Given this list of marker genes NBEA, PMEL, SLC7A6OS, PRKG2-AS1, PRC1-AS1, MROH7, TTLL4, GEN1, BEST1, PLCE1, SPART-AS1, TYRP1, PKNOX2, HMGB1P35, TMEM135, LINC01703, RBM11, TYR, GPR143, DCT, RPL32P32, SMG1P6, NYX, VEPH1, COL8A1, DMXL1, KCNQ4, UGT3A2, H1-9P, RDH5, RANBP17, ZNF92, SMC6, ENTREP1, PGPEP1L (pyroglutamyl-peptidase I like), MFRP, NTAN1P2 (N-terminal asparagine amidase pseudogene 2), SLC38A8, SGK3 (NCBI Gene Id 23678), RNU6-212P, CCT4P2, SMG1P2, WFDC1, DIRC3, SCAND3P1, TEX2, HORMAD2 (NCBI Gene Id 150280), RNA5SP229 (NCBI Gene Id 100873487), BMP7 (bone morphogenetic protein 7), TMEM235, BMP6, SMURF2P1, SERPINE3, PCAT1, RNU4ATAC17P, HORMAD2-AS1, TMEM98, UBAP1L, PARD3B, SCAI, OCA2, OBSCN-AS1, AJUBA-DT, RPL7AP22, TBC1D30, RPE65 (retinoid isomerohydrolase RPE65), LINC00605, AK5, TRIM36-IT1, SERPINF1, MITF, ACP6, ZNF890P, SOSTDC1, SLC22A8, CNGB3, SLC16A8, RAB27A, PIP4P2, DTX2P1, CNDP1, LINC02723, INPP5K, CRISPLD1, LINC02275, GSTA8P, SLEAR, RLBP1, SLC38A11, CCND2-AS1, LIN28B-AS1, DHRSX-IT1, GEM, SLC4A5 (NCBI Gene Id 57835), GAPDHP66, RNY4P36, ECHDC1, ENSG00000253778, LNCOC1, SLC39A12, ADAMTSL3, ERMN, SLC24A5, LINC03048, FYB2, GAPDHP76, TRPM7, ENSG00000231204, RN7SL846P, ENSG00000260288, LCNL1, CCNYL2, ADTRP, LINC03040, LINC01359, SLC6A20, ADAD2, PARD6B, WDR35-DT, APC, NPIPB12, ACOT11, PLD5, STARD7-AS1, SEC14L2, GUCY2EP, TMCO1-AS1, RRAGAP1-AS1, LINC01567, BCO1, MLANA (NCBI Gene Id 2315), BMS1P4, CNBD1, RGR, SILC1, EFR3B, STIM2, LINC00494, LINC01579, MIR5094, RHPN2P1, RNU6-1138P (NCBI Gene Id 106480641), RPL21P95, LINC00670, ELN-AS1, BTC, MESP2, ABCC5, USP38-DT, DOCK7-DT (NCBI Gene Id 121832810), CRPPA, PAFAH1B2P2, LINC00645, LINC01085, SLC6A13, APOLD1, HYCC1, COL9A2, DOCK7, LINC01465, ZBED3-AS1, MYRF-AS1, RNU4-16P, WFIKKN2, MAMDC2-AS1, LINC02774, PLGLA, VAT1L, CYB5RL, SPDYE5, ATXN1, SNX25, ENPP2, SLC45A2, RAD54B, IGFBP7-AS1, TBL1Y, WWC2-AS1, NPFFR1, LINC01880, FRZB, TRPM3, KCNJ13, ZBTB12, ARNT2-DT, CYP27A1, TSPAN10, COL4A3, PITPNA, ITGAV, RNF212, LINC00276, ENSG00000255746, LRP8-DT, LINC00355, PRMT7, here is a description of the gene set: from publication Cao J, O'Day DR, Pliner HA, Kingsley PD, Deng M, Daza RM, Zager MA, Aldinger KA, Blecher-Gonen R, Zhang F, Spielmann M, Palis J, Doherty D, Steemers FJ, Glass IA, Trapnell C, Shendure J (PMID 33184181) Human Gene Set: DESCARTES_MAIN_FETAL_RETINAL_PIGMENT_CELLS The gene expression program underlying the specification of human cell types is of fundamental interest. The study authors generated human cell atlases of gene expression and chromatin accessibility in fetal tissues. For gene expression, the study authors applied three-level combinatorial indexing to >110 samples representing 15 organs, ultimately profiling ~4 million single cells. The study authors leveraged the literature and other atlases to identify and annotate hundreds of cell types and subtypes, both within and across tissues. Our analyses focused on organ-specific specializations of broadly distributed cell types (such as blood, endothelial, and epithelial), sites of fetal erythropoiesis (which notably included the adrenal gland), and integration with mouse developmental atlases (such as conserved specification of blood cells). These data represent a rich resource for the exploration of in vivo human gene expression in diverse tissues and cell types. studied in species Homo sapiens Marker genes curated from the annotated cluster as represented in the Descartes Human Gene Expression During Development database.